Given this list of marker genes Cntnap2, Lmx1b, Nrxn1, Zfp365, Cacna1a, Pcnt, Ulk1, Map2k1, Gas1, Dab1, Agtpbp1, Whrn, Psap, Slc25a46, Pantr2, Skor2, Hes1, Gsx2, Wnt1, Trnp1, Tuba1a, Gli2, Cbln1, Gba1, Atxn2 (ataxin 2), Lhx1 (LIM homeobox protein 1), Coq8b, Atp7a, Dll1, Gnpat, Ldb1, Cend1, Ttll1, Rora, Dlc1 (deleted in liver cancer 1), Cdk5, Gli1, Comt, Ttc21b, Ptpn11, Ophn1, Abl2, Abl1, Grid2, Sptbn2, Kif14, Hspa5, Lhx5, Prox1 (prospero homeobox 1), Smo, Serpine2, Foxp2, Cbs, Wnt7a, Atp2b2, Hes3, Herc1, Mtpn, Kndc1, Faim2, Lrp6, Nfix, Usp9x, here is a description of the gene set: The process in which the anatomical structure of the hindbrain is generated and organized. The hindbrain is the region consisting of the medulla, pons and cerebellum. Areas of the hindbrain control motor and autonomic functions. Mouse Gene Set: GOBP_HINDBRAIN_MORPHOGENESIS studied in species Mus musculus